The following is a description of a gene set: Human Gene Set: WP_ADHD_AND_AUTISM_ASD_PATHWAYS ADHD and autism (ASD) pathways studied in species Homo sapiens, and this is the list of marker genes: CBR1, APP, SCN8A, SCN1B, MMACHC, MMUT, MAP1LC3A, AKT1S1, PIK3C3, SIRT3, QPRT, GNMT, SLC32A1, PRKACB, SYT1, FMO1, GABRQ, GRM7, SYP, CYP2C19, SLC25A32, ATG14, DRD5, FAAH2 (NCBI Gene Id 158584), IFNG, AKT2, MMADHC, AMPD1, ATG4A, NRXN3, ALDH1L1, DAGLA, AMN, SLC52A2, GKAP1, GABRG1, DLG5, PTEN, FOLR2, SLC52A1 (solute carrier family 52 member 1), ADRA1A, KCNA6, DLGAP4, GRIN2D, KYAT3, SORBS2, SHMT2, ADSL, OPRM1, CUBN (cubilin), SLC46A1, ATG101, GRIN2B, ATG13 (NCBI Gene Id 9776), RICTOR, RHEB, CDO1 (NCBI Gene Id 105379131), GRIA3, CACNG4, SOD1, ASMT, CBLIF, PIK3R2, MTHFD1, GAD1, NOS2, GRIP1, MC4R, ADRB2, GCAT (glycine C-acetyltransferase), ALDH1L2, GABRA5, GABRA3, AGTR1, CALM1, GCH1, PNMT (NCBI Gene Id 5409), DLG1, AOC1, TPH1, MTRR, SLC6A3, KCNA4, ALDH2, ATG5, HOMER2, GABRA1 (NCBI Gene Id 2554), PDGFRA, SLC52A3, GABRA4, SESN1, ADRA1B, HTR1E, ADORA2A, HTR2A, OXT, CNTNAP2, MTHFD1L, GRIN3A, SCN9A, NLGN1, TNF, MAT2B (methionine adenosyltransferase 2 non-catalytic beta subunit), PTS (6-pyruvoyltetrahydropterin synthase), SLC25A40, NOX5, KYNU, GLS2, TCN2, DHFR, GLS, CYP2C9, PRKCB, FAAH, PIK3CB (NCBI Gene Id 5291), PNP, CACNA1C, PRKCD, GABRB3, DLG2, NMNAT1, GRM2, GABRB1, SCN5A, ADAM10, CNTNAP3, DAGLB, QDPR, CTTN, SLC17A6, GRIN2C, TSC2, NOX4, AKR1C1, CACNG1, ATG2A, HTR1D, CPLX1, GRIN3B, MTHFR, GABRB2, ADSS2, SULT1A3, NOX3, DNMT1, PIK3R4, PIK3R3, PRKACG, NCAM1, ATG3, GRIN2A, STXBP1, KCNA5, IDO1, CTNNB1, CNTNAP4, SHANK2, SLC18A1, XDH, PIK3R1, PRKCZ, GNAQ, ATIC, SCN2A, PRKCA, ATG7, IDO2, WIPI1, ADGRL3, SLC6A4, GAD2, SHMT1, SCN4A, CCT6A, AGMO, SPR (sepiapterin reductase), CNTNAP1, ATG16L1, MAOB, BECN1, MMAA, NRXN1, HTR3E, PRKACA, HTR3B, TH, AKR1C3, GABRD, HTR3D, DRD4 (NCBI Gene Id 1815), KIT, GRM6, NGLY1, GRM3, STX1A, KCNA7, MTHFD2L, KYAT1, CBS, SESN2, GRIP2, ACACA, ALDH9A1, DEPTOR, GPHN, GRM5, EGFR, GABBR1, AOX1, SCN2B, NOS3, CACNG7, DGUOK, DLG3, FOLH1, OXTR, HTR6, PRKAR1B, NOX1, CNTN4, NLGN2, DAG1, TAAR1, AANAT, TPH2, KCNA2, CTH, KCNA3, RPTOR, PIK3AP1, WIPI2 (WD repeat domain, phosphoinositide interacting 2), NLGN3, PDXK, HOMER3, ACE, SLC25A13, SOD3, NOS1, NLGN4X, CD320, SCN3B, ABL1, APRT, PRKCG, INSR, RIT2, PIK3CD, MECP2, NRXN2, ALPI, IMPDH1, CNTN6, CACNG8, DBH, MTR, CSAD, SCN7A, AKR1B1, SCN3A, ATG12, CYP3A4, PCBD2, DLGAP5, CYP2D6, PLCG2, MAPKAP1, ULK1, CBL, HNMT, GRM1, ADRA1D, MAT1A, GRM4, PCBD1, MAOA, CNTN3 (NCBI Gene Id 57632), DLG4, AKT1, TCN1, ALPL, ABCD4, GRIA4, SHANK1, ADA, SCN4B, AKT3, MTOR, AKR1A1, ABL2, GABRA2, TSC1, MLST8, GATM, SCN1A, DLGAP2, ITPA, CNTN2, SLC25A12, GRIA1, PRKAA2, WDR45, SLC6A2, CNR1, GK, PLCG1, CNR2, ABAT, TDO2, PAH (NCBI Gene Id 5053), SCN11A, NADSYN1, CACNG6, MTHFD2, SOD2 (superoxide dismutase 2), DDC, RFK, DLGAP3, PRKAA1, GRIN1, RHOA, MOCOS, SLC25A39, GOT2, HTR2B, TYMS, AADAT (aminoadipate aminotransferase), PTK2B, HTR1F, CACNG2, PIK3CA (NCBI Gene Id 5290), CNTN1, DLGAP1, HCFC1, SLC6A1, HTR7, SCN10A, DRD2, HPRT1, AHCY, LMBRD1, GABRG2, SNAP25, PRKAR2B, SLC19A1, GRM8, GLUL, FOLR1 (folate receptor alpha), REN, HDC, RB1CC1, COMT, VAMP2, GRIA2, PNPO (NCBI Gene Id 55163), ATG10, STK11, CACNG5, KMO, BHMT, HOMER1, HTR4, CNTN5, HTR3C (5-hydroxytryptamine receptor 3C), PDGFRB, KCNA1, CACNG3, PRKAR1A